Given this list of marker genes Mbtps2, Mitd1, Gm11507, Rab12, Tango2 (NCBI Gene Id 27883), Fam149b, Rnu11, Pgk1, Ubald1, Hdac7, Mrpl30, Golga7, Smg7, Mtf2, Mrpl39, Cped1, Ap1g1, Acat1, Skida1, Cltc, here is a description of the gene set: studied in species Mus musculus from publication Yevshin I, Sharipov R, Kolmykov S, Kondrakhin Y, Kolpakov F (PMID 30445619) Mouse Gene Set: GM20449_UNIPROT_E9Q3U2_UNREVIEWED_TARGET_GENES